The following is a description of a gene set: Human Gene Set: GOMF_RIBOSOMAL_LARGE_SUBUNIT_BINDING species: Homo sapiens Binding to a large ribosomal subunit., and this is the list of marker genes: MTRFR, NEMF, DHX33 (DEAH-box helicase 33), MPV17L2, LTN1, MIURF, RBM3, CPSF6, MTRES1, CPEB2 (NCBI Gene Id 285549), EIF6, OLA1, NDUFAB1 (NCBI Gene Id 4706), MALSU1, MRRF, NPM1, NMD3